The following is a description of a gene set: from publication Yao MW, Lim H, Schust DJ, Choe SE, Farago A, Ding Y, Michaud S, Church GM, Maas RL (PMID 12554760) Human Gene Set: YAO_TEMPORAL_RESPONSE_TO_PROGESTERONE_CLUSTER_15 Genes co-regulated in uterus during a time course response to progesterone: SOM cluster 15. studied in species Mus musculus Human infertility and recurrent pregnancy loss caused by implantation defects are poorly understood. Hoxa-10-deficient female mice have severe infertility and recurrent pregnancy loss due to defective uterine implantation. Gene expression profiling experiments reveal that Hoxa-10 is an important regulator of two critical events in implantation: stromal cell proliferation and local immunosuppression. At the time of implantation, Hoxa-10 mediates the progesterone-stimulated proliferation of uterine stromal cells. Hoxa-10 mutants express a stromal cell proliferation defect that is accompanied by quantitative or spatial alterations in the expression of two cyclin-dependent kinase inhibitor genes, p57 and p15. Hoxa-10 deficiency also leads to a severe local immunological disturbance, characterized by a polyclonal proliferation of T cells, that occurs in place of the normal progesterone-mediated immunosuppression in the periimplantation uterus., and this is the list of marker genes: PCLAF, STMN1, LUM, ITM2A, GRN, AURKB, NPC1, CDK1, BIRC5, DNASE1L2, ALOX15, COL4A5, PCK2, CRYZ, PTPRD, SEPTIN10, EPOR, SEMA3C, CD59, GAB1, ROBO1, MTERF2, HEPH, SEMA3B, COL14A1, NICOL1, MKI67, SLC15A2, KIF22 (NCBI Gene Id 728037), PLAC8, GSTT1, ST3GAL6, XPA, NSG2, POSTN